The following is a description of a gene set: species: Homo sapiens from publication Schenk M, Krutzik SR, Sieling PA, Lee DJ, Teles RM, Ochoa MT, Komisopoulou E, Sarno EN, Rea TH, Graeber TG, Kim S, Cheng G, Modlin RL (PMID 22447076) Human Gene Set: GSE34156_TLR1_TLR2_LIGAND_VS_NOD2_AND_TLR1_TLR2_LIGAND_24H_TREATED_MONOCYTE_UP Genes up-regulated in monocytes (24h): M. tuberculosis 19 kDa lipopeptide versus M. tuberculosis 19 kDa lipopeptide and muramyl dipeptide. human blood monocytes were isolated, activated and harvested at several timepoints In this study, we identified genes that were differentially expressed in human monocytes activated with eiter NOD2L and/or TLR2/1L., and this is the list of marker genes: RAC1, C15orf48, KAZALD1, MPEG1, GRN, DAPP1, CD93, IFI30, HCK, PLEKHO2, SLC37A2, GK (NCBI Gene Id 2710), DUSP6, VCAN, PSAP, ANPEP, PLAU, VRK2, OS9, TLX3, NCOA4, TMCC3 (transmembrane and coiled-coil domain family 3), HPGDS, GK3, CLPTM1L, SULF2, NADK, FUOM, FCGRT, HPSE, FCGR2C, DMXL2 (NCBI Gene Id 23312), SLC25A37, VPS37C, TNS3, KCNJ2, IGSF6, ACTB (NCBI Gene Id 60), KYNU, SIRPA, CD163, CD86, NLRP7, MGST1, FCGR2A, LILRB3, CTSZ, ABCD1, FLJ12825, KLRB1, EPB41L3, PITPNA, C12orf56, TIMP1, ATP13A3, CYBB, LACC1, MPP1, HLA-DRB4, CXCL1, ELF4, FERMT3, FTL, PILRA, CD151, HOXA2, PLXNB2, ATP6V1B2, TYROBP, TLR4, LINC03025, NRP2, TLN1, SLAMF9 (SLAM family member 9), TLR2, CLIC4, DSE, LGALS2, NLRP14, CLEC4E, CREG1, NCF2, TFEC, LRP1, TGFBI, CARD19, MERTK, DCBLD2, PMP22, CLIC1 (NCBI Gene Id 257617), MAP4K3, FPR2, CD14, RAB5A, P2RX7, TMEM51, DOK3, ZNF385A, ADAM9, LGALS3, ACTR2, GBA1LP, DOCK4, SLC16A6, PPARG, HCAR3, CHIA, PTPRE, P2RX4, HMOX1, CD300LF, SRC, BRI3, CCDC88A, NCF1C (NCBI Gene Id 654817), RRBP1, UBE2Z, MYOF (NCBI Gene Id 26509), SFTA3 (NCBI Gene Id 253970), CCR1, ADAM28 (NCBI Gene Id 27337), ANXA5, KCNMB1, NRM, MEFV, CXCL16, DUSP3, MARCKS, LYN, CYTH3, LMO2, RNF130, PLEKHN1, NCAPG, RIN2, CHST15, CAPG, AKR1D1, VEGFA, CXCL3, FCAR, SLC11A1 (NCBI Gene Id 6556), RGS19, RAB31, BCAT1, NID1, LILRB2, GPR157, NABP1, CSF2RB, LGALS9, RBM47, GLUL, RAB7A, LORICRIN, SRA1, WARS1, IFNGR1, SFXN5, PSTPIP2, SAT1 (spermidine/spermine N1-acetyltransferase 1), IRF5, LIMS1, TPM4, RAB2A, IL13RA1, CTSL, CYP27A1, PTAFR, CSF2RA, C3AR1, RCOR2, LHFPL2, GNB4 (NCBI Gene Id 59345), TALDO1, CSF1R, GNS, ASAH1, FAM89B, WDFY3, SYK, OSCAR, ADGRE2, NCF4, CTSD, GM2A, FLOT1, CORO1C, LILRB4, MAFB, LAT2, ADAMTS19, NCS1, MSR1 (NCBI Gene Id 4481), LILRA6, PRKCE